Given this list of marker genes Tyro3, Lamc1, Fga, Col8a1, Madcam1, Cd34, Tsc1, Nedd9, Ccl25, Sema3e, Itga5 (NCBI Gene Id 16402), Adam15, Col1a1, Pxn, Fut1, Zyx, Bcl6, Iqgap1, Dicer1, Col16a1, Clasp2, Tbcd, Npy, Itga3, Zfp469, Kif14, Hacd1, Abi3bp, Hoxa7, Fmn1, Efna5, Itga1, Itgam, Spry4, Plg, Ccl21f, Fbln1, Ptprj, Lrp1, Cass4, Men1, Dock5, Pdpn, Tek, Slk, Crk, Tnn, Ntn4, Lgals1, Npnt, Epdr1, Sfrp1, Vwf, Col5a3, Wdpcp, Trem1, Alox15, Pcsk5, Prkce, Mmp12, Dmd, Myadm, Micall2 (NCBI Gene Id 231830), Itgax, Itga9, Nrp1, Wnt1, Angptl3, Parvb, Gcnt2, Pik3cb, Dmtn, Skap1, Myh9 (NCBI Gene Id 97972), Rac2, Ptprz1, Atp1b2, Hoxd3, Ptprk, Ccdc80, S100a10, Onecut1, Crkl, Ldb1, Rreb1, Itgb1, Smoc1, Bcl2, Col3a1, Ccl21d, Arpc2, Gp5, Ppard, Sdc4, Ccl21e, Rhod, Mslnl, Cdc42, Rin2, Pkhd1, Arl2, Plekha2, Ptpn11, Rhoa, Vwa2, Ccl28, Axl, Bves, Enpp2, Bcar1, Fgb, St6gal1, Spock1, Ilk, Unc13d, Vit, Thy1, Cfl1, Smoc2, Dapk3, Poldip2, Arhgap6, Map4k4, Srf, Ptpn1, Plpp3, Tnfrsf12a, Taok2, Lama5, Bcl2l11, Akip1, Bcr, Mdk, Has2 (NCBI Gene Id 210441), Olfm4, Efemp2, Acer2, Itgae, Itga6, Smad3 (NCBI Gene Id 17127), Coro1c, Itgb6, Sned1, Prkcz, Rasa1, Pip5k1a, Fzd4, Itga2, Prex1, Jup, Apod, Emp2, Adamts12, Limch1, Rras, Vwc2, Antxr1 (anthrax toxin receptor 1), Itgb7, Muc21, Rpl29, Mink1, Vcl, Ptpra, Ndnf, Ninj1, Postn, Col13a1, Itga10, Notch1, Ccl21b, Ajuba, Otoa, Lims1, Itgal, Pdpk1, Fermt2, Gpm6b, Dab2, Nf1, Macf1, Rac1, Anxa2, Epha3, Sirpa, Jak2, Egflam, Itgb2, Gfus, Itgb8, Gas6, Egfl6, Trpm7, Cdh11, Bcan, Rell2, Cd63, Cripto, Vegfa (NCBI Gene Id 22339), Parva, Vamp3, Actn1, Spock2, P4hb, Dbn1, Flna, Jam3, Hrg, Fat2, Nexmif, Stk4, Fzd7, Cdkn2a, Mia, Coro2b, Rhpn1, Tmem8b, Meltf, Ttyh1, Ddr1, Mmp14, Lamb1, Smad6, Col26a1, Epha1, Acvrl1, Ptk2, Megf9, Ctnnb1, Vtn, Cd3e (CD3 antigen, epsilon polypeptide), Lypd3, Itga11, Dnm2, Itgad, Bst1, Cspg5, Dlc1, Fn1, Clasp1, Nid2, Thsd1, Thbs1, Fam107a, Hsd17b12 (NCBI Gene Id 98865), Vcam1, Adamts9, Onecut2, Myo1g, Ccn1, Strc, Itga4, L1cam, Ap1ar, Lpxn, Pkp2, Actg1, Fermt3, Cask (NCBI Gene Id 236691), Actn4, C1qbp (complement component 1, q subcomponent binding protein), Kdr, Dusp3, Ptn, Foxf1, Pik3r1, Eda, Lamb3, Msln, Agr2, Tnxb, Svep1, Ephb1, Myoc, Fer, Spp1, Gsk3b, Ccl21a, Apoa1, Mkln1, Pecam1, Sec1, Cdh13, Tiam1, Ppm1f, Itga2b, Camsap3 (calmodulin regulated spectrin-associated protein family, member 3), Bcam, Tacstd2, Rab1a, Itgbl1, Fndc3b, Tesk2, Ephb3, Itga8, Braf, Dmp1, Cd96, Jag1, Ajap1, Cd36 (CD36 molecule), Ccn2, Itgav, Csf1, Spag6l, Triobp, Efna1, Cib1, Calr, Hpse, Emilin1, Dag1, Abl1, Muc4, Phldb2, Itgb4, Itgb5, Epb41l5, Marcks, Grem1, Itgb2l, Kank1, Sorbs1, Plet1, Actn2, Itga7, Angpt1, Coro1a, Actn3, Ptk2b, Angpt2, Mertk, Plau, Tesk1, Disc1, Parvg, Ecm2, Fbln2, Utrn, Adam8, Cttn, Whamm, Myf5, Rac3, Rock1, Edil3, Fermt1, Peak1, Agt, Carmil1, Cdk6, Nid1, Prkx, Dusp22, Pdgfb, Cdk5, Rcc2, Frem1, Lamb2, Tecta, Serpine1, Srcin1, Npy2r, Cntn2, Adam9, Rsu1, Lims2, Itgb1bp1, Itgb3, Atxn3, Sorbs3, Pten, Src, Wnt4, Ston1, Dock1, Fgg, Radil, here is a description of the gene set: studied in species Mus musculus The attachment of a cell to the underlying substrate via adhesion molecules. Mouse Gene Set: GOBP_CELL_SUBSTRATE_ADHESION